The following is a description of a gene set: Hepatocyte nuclear factor 4alpha (HNF4alpha) is a tissue-specific transcription factor known to regulate a large number of genes in hepatocytes and pancreatic beta cells. Although HNF4alpha is highly expressed in some sections of the kidney, little is known about its role in this organ and about HNF4alpha-regulated genes in the kidney cells. The abundance and activity of HNF4alpha are frequently reduced in renal cell carcinoma (RCC) indicating some tumor suppressing function of HNF4alpha in renal cells. To determine the potential role of HNF4alpha in RCC, we used Flp recombinase-mediated gene integration to generate human embryonic kidney cells (HEK293) that conditionally express wild-type or mutated HNF4alpha. Expression of wild-type HNF4alpha but not of the mutants led to reduction of proliferation and alterations of cell morphology. These effects were reversible and induced at physiological concentrations of HNF4alpha. Using gene expression profiling by microarrays, we determined genes regulated by HNF4alpha. Interestingly, many of the genes regulated by HNF4alpha have been shown to be deregulated in RCC microarray studies. These genes (ACY1, WT1, SELENBP1, COBL, EFHD1, AGXT2L1, ALDH5A1, THEM2, ABCB1, FLJ14146, CSPG2, TRIM9 and HEY1) are good candidates for genes whose activity is changed upon the decrease of HNF4alpha in RCC. species: Homo sapiens Human Gene Set: LUCAS_HNF4A_TARGETS_DN Genes down-regulated in Tet-On HEK293 cells (embryonic kidney) by expression of HNF4A. from publication Lucas B, Grigo K, Erdmann S, Lausen J, Klein-Hitpass L, Ryffel GU (PMID 16007190), and this is the list of marker genes: GAS1, NEFL, VCAN, ABCC4, BRD3OS, HEY1, LGR5, TRIM9